The following is a description of a gene set: Any process that activates or increases the rate or extent of cell adhesion to another cell. Human Gene Set: GOBP_POSITIVE_REGULATION_OF_CELL_CELL_ADHESION studied in species Homo sapiens, and this is the list of marker genes: CD1D, DPP4, TESPA1, CX3CL1, ACTB, IL23A, YWHAG, PKP1, KIFAP3, NCKAP1L, FUT7, PTPN11, ALOX5, CD46, CR1, SOX4, LEP, RARA, LGALS8, CORO1A, BRD7, PIEZO1, CXCL13, RELA, CD27, SKAP1, IL12B, NODAL, TYK2, IGFBP2, CD70, NOD2, PDCD1LG2, EPO, ETS1, FYN, HLA-DRB1, NR5A2, SMARCA4, AIF1, EFNB3, XCL1, MIR21, MAP3K8, HLA-DQB2, EP300, HLA-DPA1, HLA-DOB, KLHL22, HSPD1, ST3GAL4, CHST2, TNFRSF13C, ELANE, KLRK1, FGB, HLA-DQA2, WNT3A, FGA, SELENOK, BTNL2, RAG1, PIK3R6, PKP3, IL6R, IL12A, CD5, CBFB, WNT5A, AFDN, MMRN1, LEF1, ZBTB7B, CCL5, RNASE10 (NCBI Gene Id 493622), CD6, DENND6A, HSPH1, ITGA4, IL4I1, IL12RB1, CYLD, VAV1, MIR30B, MTOR, ANK3, VCAM1, BAD, SMARCD3, KITLG, FOXA2 (NCBI Gene Id 3170), CAV1, VNN1, CD74, AP3D1, ICOS, TGFB1, CLECL1P, FGG (NCBI Gene Id 2266), JAK2, BCL10, TNFSF4, HLA-DQB1, AP3B1, MDK, SMARCE1, HLA-DRB5, FUT3, HTN1, NFKBIZ, CD3E, TNFRSF14, HHLA2, RIPK2, FBXO38, DUSP10, HLA-DRB3, SOX2, HLA-DMB, RUNX3, NFKBID, HLA-A, GLI3, IL1B, YES1, DOCK8, NKAP, ZBTB16, ACTL6A (actin like 6A), TJP1, HLA-DQA1 (NCBI Gene Id 7946), ADAM19, CD276, KIF26B, CCR2, ZP4, SRC, HAVCR2, SLAMF1, CARD11, PLPP3, PRKCZ, PDPK1, IL6ST, SMARCD1, PYCARD, SLC7A1 (NCBI Gene Id 6541), ARID1A, IL23R, GPR65, CD47, IL2RG, SOCS5, SPTA1, CD24, TNFSF13B, PODXL, CD86, TNFSF9, CCL21, ZAP70, CITED2, EGR3, HLA-G, FSTL3, PLAUR, SOCS1, CD81, ABL1, IL1A, PCK1, PTPN23, SELP, CCDC88B, CEACAM6, BRD4, FLOT2, F11R, PDPN, HTR2A, ZP3, ARID2, PTPN6, CTSG, RPS3, IFNG, RASGRP1, CD160, CCL19, STAT5B, IL15, ADA, TGFBR2, PBRM1, DNAJA3, SIRPG, FUT4, SOX12, TNFSF11, HES1, CD40LG, CD55, PRKAA1, ABL2, AGER, BMP7, STAT5A, MALT1, TNFSF14 (NCBI Gene Id 94566), EFNB2, HLA-E, AKT1, PTPRC, SMARCC1, RASAL3, IGF2, TNF, MIR92A1, MFSD2B, ADAM8, SMARCD2, NFAT5, IL7, GCNT1, SMARCB1, LCK, EMILIN1, LYN, LILRB4, ZBTB1, PNP, FLOT1, BMI1, EFNB1, ZMIZ1, CD83, OPA1, ANXA1, AMBRA1, CTNNB1, SMARCC2, IL1RL2 (NCBI Gene Id 8808), SPN, SOX13, LGALS9, SHB, FOXP3, SART1, PRKCQ, GP6, GPAM, PPP3CA, IL2, ITPKB, MEGF10, FOXA1, IL4, SELE, HLA-DOA (major histocompatibility complex, class II, DO alpha), CSK, IHH, SMARCA2, TRAF6, HLA-DPB1, CHST4, LILRB1, CYRIB, BRD2, IL10, SHH (NCBI Gene Id 6469), NCK2, HLA-DRB4, WNT10B, MYO10, BTN2A2, KAT5, CCL2, VTCN1, LILRB2, NR4A3, BCL6, SIRPB1, FCHO1, SMAD7, CD209, EBI3, HLA-DMA, HAS2 (hyaluronan synthase 2), RAP1GAP, B2M, MAGI1, CD80, EMILIN2 (elastin microfibril interfacer 2), CD28, CD4, ACTL6B (actin like 6B), KLRC4-KLRK1, NLRP3, IL18, TMIGD2, GLI2, RHOA, HMGB1, SERPINF2, FOXO3, CCR7, KLHL25, IL6, PIK3CD, ICOSLG, THY1, HLX, TFRC, IRAK1, IL2RA, RUNX1, XBP1, NCK1, GCNT2, PTPRU, ITGB2, PHF10, IL36B, SIRPA (signal regulatory protein alpha), FADD, IL21, SASH3, RHOH, SYK, ARID1B, LGALS1, IL4R, IL7R, HLA-DRA, CD44, JAK1, GATA3, CD274, VSIR, DHPS, IGF1